Given this list of marker genes IGF1, LEP, GCG, SPCS3, SEC11C, GHRL, SPCS2, CRHR2, PCSK1 (NCBI Gene Id 5122), MBOAT4, SPCS1, GH1, KLF4, SEC11A, UCN (urocortin), PLA2G7, BCHE, ACHE, INS, here is a description of the gene set: Reactome Pathway: Synthesis, secretion, and deacylation of Ghrelin studied in species Homo sapiens Ghrelin is a peptide hormone of 28 amino acid residues which is acylated at the serine-3 of the mature peptide. Ghrelin is synthesized in several tissues: X/A-like cells of the gastric mucosa (the major source of ghrelin), hypothalamus, pituitary, adrenal gland, thyroid, breast, ovary, placenta, fallopian tube, testis, prostate, liver, gall bladder, pancreas, fat tissue, human lymphocytes, spleen, kidney, lung, skeletal muscle, myocardium, vein and skin. Ghrelin binds the GHS-R1a receptor present in hypothalamus pituitary, and other tissues. Binding causes appetite stimulation and release of growth hormone. Levels of circulating ghrelin rise during fasting, peak before a meal, and fall according to the calories ingested.<br>Preproghrelin is cleaved to yield proghrelin which is then acylated by ghrelin O-acyltransferase to yield octanoyl ghrelin and decanoyl ghrelin. Only octanoyl ghrelin is able to bind and activate the GHS-R1a receptor. Unacylated ghrelin (des-acyl ghrelin) is also present in plasma but its function is controversial.<br>Acyl proghrelin is cleaved by prohormone convertase 1/3 to yield the mature acyl ghrelin and C-ghrelin. Secretion of ghrelin is inhibited by insulin, growth hormone (somatotropin), leptin, glucose, glucagon, and fatty acids. Secretion is stimulated by insulin-like growth factor-1 and muscarinic agonists.<br>In the bloodstream acyl ghrelin is deacylated by butyrylcholinesterase and platelet-activating factor acetylhydrolase. Other enzymes may also deacylate acyl ghrelin. part of: Peptide hormone metabolism